Given this list of marker genes HMGCL, HTRA2, OPA3, TIMM50, DNAJC19 (NCBI Gene Id 131118), here is a description of the gene set: 3-Methylglutaric aciduria Human Gene Set: HP_3_METHYLGLUTARIC_ACIDURIA An abnormally increased level of 3-hydroxy-3-methylglutaric acid in the urine. species: Homo sapiens